The following is a description of a gene set: Tendon reflexes that are noticeably more active than usual (conventionally denoted 3+ on clinical examination). Brisk reflexes may or may not indicate a neurological lesion. They are distinguished from hyperreflexia by the fact that hyerreflexia is characterized by hyperactive repeating (clonic) reflexes, which are considered to be always abnormal. studied in species Homo sapiens Brisk reflexes Human Gene Set: HP_BRISK_REFLEXES, and this is the list of marker genes: NR4A2, CARS1, SLC9A7, BSCL2, SLC52A3, SPG11, COG5, EXOSC9, WDR62, ITPR1, COX5A, MT-TN, NDUFA4, WDR4, FUCA1, GDAP2, JAM2, COX10, REEP1, IMPDH2 (inosine monophosphate dehydrogenase 2), SCN1A, BCAT2, NDUFS8, GRM1, RNF170 (NCBI Gene Id 96586), PI4K2A, REPS1, ALDH18A1, PIGA, GTPBP2, MT-TL2, NFU1, CNBP, VCP, GEMIN5, CHMP1A, PARK7, PPP1R15B, GLYCTK, FUS, ALS2, PRR12, GCH1, ELN, PEX16, PMPCA, CNP, PPIL1 (peptidylprolyl isomerase like 1), MRPS25, DARS1, SMG9, SURF1, CADM3, SPTLC1, H4C5, GNS, ABCB7, LYRM7, MSTN, GLE1, SIGMAR1, IER3IP1, NFIX, TANGO2, ATP13A2, TRMT10A, FTL, POU4F1 (POU class 4 homeobox 1), PLA2G6, VRK1, FBLN5, SLC6A5, PDE8B, KCNMA1, TSPOAP1, PKDCC (NCBI Gene Id 91461), SLC16A2 (NCBI Gene Id 6567), PAK3, PEX19, RNASEH1, CDC40, ATG5, ERCC1, ELOVL1, ADSL, CAMTA1, SPAST, ANO10, AASS (aminoadipate-semialdehyde synthase), COX11, TH, DLAT, TUBGCP2, COQ8A, SPTBN1, HARS1, SET, MMAA, SLC39A14, TBCD, MT-TL1, SMC5, PITRM1, GBA2, TMEM106B, LETM1, COQ5, SLC1A4